The following is a description of a gene set: Cytokines mediate cell-cell communication in the immune system and represent important therapeutic targets. A myriad of studies have highlighted their central role in immune function, yet we lack a global view of the cellular responses of each immune cell type to each cytokine. To address this gap, the authors created the Immune Dictionary, a compendium of single-cell transcriptomic profiles of more than 17 immune cell types in response to each of 86 cytokines (>1,400 cytokine-cell type combinations) in mouse lymph nodes in vivo. A cytokine-centric view of the dictionary revealed that most cytokines induce highly cell-type-specific responses. For example, the inflammatory cytokine interleukin-1β induces distinct gene programmes in almost every cell type. A cell-type-centric view of the dictionary identified more than 66 cytokine-driven cellular polarization states across immune cell types, including previously uncharacterized states such as an interleukin-18-induced polyfunctional natural killer cell state. Mouse Gene Set: CUI_TREG_IL_Y_RESPONSE_DN species: Mus musculus Genes negatively differentially expressed in cell type: Treg upon treatment with cytokine: IL-Y in mouse lymph nodes in vivo. from publication Cui A, Huang T, Li S, Ma A, Pérez JL, Sander C, Keskin DB, Wu CJ, Fraenkel E, Hacohen N (PMID 38057668), and this is the list of marker genes: Jun, Klf6, Hspa1b, Uba52, Dusp1, Hspa1a, Hspa8